The following is a description of a gene set: Any process that modulates the frequency, rate, or extent of mast cell activation as part of an immune response. Mouse Gene Set: GOBP_REGULATION_OF_MAST_CELL_ACTIVATION_INVOLVED_IN_IMMUNE_RESPONSE studied in species Mus musculus, and this is the list of marker genes: Fer, Sphk2, Enpp3, Lilrb4a, Ptpn6, Cd300a